The following is a description of a gene set: species: Mus musculus The expansion of a hematopoietic stem cell population by cell division. A hematopoietic stem cell is a stem cell from which all cells of the lymphoid and myeloid lineages develop. Mouse Gene Set: GOBP_HEMATOPOIETIC_STEM_CELL_PROLIFERATION, and this is the list of marker genes: Pim1, Wnt1, Wnt5a, Wnt2b, Sfrp2, Irgm1, Dab2, Sart3, Prl2c3, Tsc22d1, N4bp2l2, Fubp1, Eif2ak2, Atxn1l, Xrcc5, Wnt10b, Nkap, Mir145b, Ythdf2, Pdcd2 (programmed cell death 2), Ercc2 (excision repair cross-complementing rodent repair deficiency, complementation group 2), Arih2, Gba1, Thpo (NCBI Gene Id 21832), Babam1, Terc, Etv6, Yjefn3 (NCBI Gene Id 234365), Brca2, Cd34, Prg4, Kat7, Mir143, Mir145a, Mecom, Cxcl1, Hoxb4, Snai2, Ctc1, Shb, Ang, Cebpa, Kitl, Ace (angiotensin I converting enzyme)